The following is a description of a gene set: Mouse Gene Set: GOMF_ACTIVE_TRANSMEMBRANE_TRANSPORTER_ACTIVITY Enables the transfer of a specific substance or related group of substances from one side of a membrane to the other, up the solute's concentration gradient. The transporter binds the solute and undergoes a series of conformational changes. Transport works equally well in either direction. studied in species Mus musculus, and this is the list of marker genes: Slc2a4, Slc5a5, Slc6a12, Slc11a1, Atp6v1c2, Slc46a3, Abcb9, Ndufs1, Ghitm, Slc20a2, Slc10a4-ps, Abca16, Slc4a8, Slc30a10, Atp6v0a1, Slc26a3, Slc1a1, Ndufa2, Slc10a3, Atp6v0e, Slc15a2, Slc22a30, Ralbp1, Slc25a42, Atp7b, Slc44a1, Abca4, Atp6v0a2, Atp2a1, Slc35e2, Slco3a1, Tomm20, Slc12a7, Atp13a2, Slc4a5, Atp6v0a4, Slc25a15, Slc26a1 (solute carrier family 26 (sulfate transporter), member 1), Slc6a17, Atp1a4, Slc12a6, mt-Nd1, Slc39a8, Abcb1b, mt-Cytb, Slc30a5, Slc37a1, Abcg2, Abca15, Slc12a8, Slc16a13, Slc6a3, Slc25a30, Slc5a12, Abcb7, Slc25a26, Slc22a29, mt-Nd2 (NCBI Gene Id 99241), Slc3a2, Cyc1, Ndufs4, Atp13a4, Slc28a2b, Slc39a14, Abca2, Atp2b2, Slco1a1, Slc38a1, Slc6a8, Slc25a22, Ndufv2, Slc10a7, Slc30a4, Slco1b2, Cybrd1, Slco1a6, Atp6v1e1 (ATPase, H+ transporting, lysosomal V1 subunit E1), Slc22a8, Ank, Abcg1, Slc37a2, Slc41a3, Atp13a5, Atp6v1h, Abca1, Slc9a1, Cox4i2, Abcc6, Slc35a2, Tmco3 (NCBI Gene Id 97481), Atp6v0e2, Slc9a4, Slc38a5, Abcc3, Cyb561d1, Ndufa10, Slc17a9 (solute carrier family 17, member 9), Slc25a12, Slc6a11, Slc38a3, Slco4a1, Slc17a6, Slc16a14, Abcc10, Slc9a7, Slc22a26, Abca9, Slc28a3, Slc26a2, Slc25a1, Atp13a1, Atp6v1b2, Abcc9, Slc6a4, Abcd3, Mfsd12, Atp1b2, Slc29a4, Slc16a12, Slc1a2, Slc18b1, Slc35e3, Slc47a2, Atp6v0d2, Slc22a1, Slc20a1 (NCBI Gene Id 99037), Atp6v1g3, Tap2, Uqcrfs1, Slc8b1, Slc1a5, Abcg4, Slc22a3, Slc17a7, Slc25a4, Slc10a1, Atp2c2, Slc26a5, Slc22a27, Slc22a5, Tmem241, mt-Nd6, Slc36a3, Slc6a1, Slc7a13, Uqcrh, Uqcrh-ps1, Anxa5, Slc6a19, Atp7a, Slc4a11, Tmem165, Slc6a14, Slc25a13, Slc12a4, Slc18a2, Slc30a2, Slc4a10, Slc9a6, Slc19a1, Slc17a4, Atp6v1e2, Slc36a4, Slc5a11, Slc25a18, Slc12a1, Atp1a2, Slc16a4 (NCBI Gene Id 99892), Slc35c2, Slc25a31, Slc25a14, Slc12a3 (solute carrier family 12, member 3), Abcd1, Slc9b2, Slc35c1, Slc35b2, Slc39a12, Slc5a2, Cyb561a3, Slco1a4, Slc5a10, Slc29a3, mt-Co1, Slc4a4, Clcn6 (NCBI Gene Id 26372), Cftr, Atp2b1, Abcb5, Slc9a9, Slco1a8, Abca6, Atp6v1g1, Slc12a9 (solute carrier family 12 (potassium/chloride transporters), member 9), Slco2a1, Slc25a19, Atp6v1f, Slc22a18 (NCBI Gene Id 18400), Slc28a2, Slc35d2, Clcn7, Slc44a2, Slc46a1, Slc32a1, Ipo8, Slc1a6 (solute carrier family 1 (high affinity aspartate/glutamate transporter), member 6), Slc4a9, Slc15a5, Abca5, Slc16a5, Slc45a2, Clcn5, Slc35e1, Slc6a20b, Abca12, Slc15a4, mt-Co2, Abca17, Slc2a13, Slc6a7, Clcn3, Slco4c1, Surf1, Atp2b4, Slc10a2, Slc18a3, Bcs1l, Slc12a5 (NCBI Gene Id 57138), Slc1a7, Slc25a5, Slc6a20a, Slc25a17, Slc8a3, mt-Nd4, Mfsd1, Abcb10, Slc13a2, Atp4a, Abcg8, Slc39a5, Slc17a2, Chp1, Slc6a9, Slc30a8, Slc6a6, Slc22a28, Slc26a4, Slc30a3, Slc44a4, Slc38a2, Abcb6, Atp2a2, Slc25a24, Slc24a4, Slc10a4, Clcn4, Slc4a1, Slc25a3, Slc47a1, Slc4a2, Slco1c1, Slc9a3, Ndufs3, Slc45a4 (NCBI Gene Id 223608), Slc16a10, Atp1b3, Slc9a8 (NCBI Gene Id 98868), Slc8a1, Slc45a3, Slc17a8, Slc25a11, Slc16a3, Gm5134 (NCBI Gene Id 333669), Abcc2, Slc4a3, Slc25a25, Atp6v0c, Atp5f1e, Abcc12, Slc41a1, Slc30a9 (NCBI Gene Id 76440), Slc26a11, Slc16a11, Slc22a4, Slc2a8 (solute carrier family 2, (facilitated glucose transporter), member 8), Atp6v1d, Abcg5, Slc29a1, Slc15a1, Slc22a6, Slc35b1, Slc35d1, Slc4a7, Slc6a5, Slc24a2, Abcc4, Abcc5 (ATP-binding cassette, sub-family C member 5), Slc39a10 (solute carrier family 39 (zinc transporter), member 10), Slc26a9, Slc10a5, Slco2b1 (NCBI Gene Id 28246), Slc26a7, Slc7a6, Slc26a10, Slc39a6, Atp5mg, Slc6a18, Slc22a2, Tmem94, Cox5a, Slc22a19, Ndufs2, Slc23a1, Slc22a7, Atp6v1a, Abcb1a, Slc35b3, Atp1b1, Abcb4, Slc7a11 (NCBI Gene Id 99638), mt-Co3, Atp1a3, Atp4b, Slc28a1, Slc35a3, Letm1, Ndufs7, Abcd2, Slc13a1, Slc16a7, Kcnj11, Slc5a8, Slc9a2, Abca13, Mfsd2a, Abcb11, Slc13a5, Tap1, Ndufv1, Slc6a13, Atp2a3, Slc7a8, Slc26a8, Slc9a5, Abca8a, Atp2b3, Atp6v0b, Slc17a1, Mcu, Abca3, Ndufs8, Atp6v0d1, Slc34a1, Slc5a1, Slc25a21, Mfsd2b, Atp6v1c1, Xpr1, Slc34a3, Slc13a3, Slc5a4b, Abcg3, Slc37a4, Slc1a3, Slc16a8, Slc35d3, Slco5a1 (NCBI Gene Id 98178), Nnt, Slc44a5, mt-Nd5 (NCBI Gene Id 78362), Slc23a2, Slc35a5, Ctns, Slc16a2, Slc15a3, Slc16a1, Slc24a3, Slc38a4, Cyb561d2, Slc38a7, Slco1a7, Slc35a1, Abcd4, mt-Nd4l, Abca7, Abca14, Atp5f1b, Atp6v1g2, Abcc8, Slc24a1, Atp12a, Slc12a2, Slc5a9, Cpox, Slc25a16, Slc10a6, Slc25a23, Slc11a2, Slc1a4, Slc17a5 (NCBI Gene Id 76855), Cdh17, Mfsd4b1, Slc35e4, Atp13a3, Slc5a3, Cox7a1 (NCBI Gene Id 12865), Slc7a9, Slc24a5, Abcc1, Slc9b1, Slc36a1, Slc9c1, Abca8b, Slc25a10, Slc6a2, Kcnj8 (NCBI Gene Id 16523), Slco1a5, Slco6d1, Slc36a2, Slc26a6, Slc5a6, Ndufb7, Slc8a2, Abcb8, Slc34a2, Ucp2, Slc5a4a, Atp6v1b1, Slco6c1, Slc6a15 (NCBI Gene Id 319850), Atp2c1, Slc18a1, Slc45a1, Slc5a7, Slc13a4, Slc7a5, Atp1a1, mt-Nd3, Slc39a4, Slc30a1